The following is a description of a gene set: Human Gene Set: GSE29618_BCELL_VS_MONOCYTE_DN species: Homo sapiens Systems vaccinology has emerged as an interdisciplinary field that combines systems wide measurements and network and predictive modeling applied to vaccinology. Here we used the systems vaccinology approach to study the molecular mechanisms underlying th from publication Nakaya HI, Wrammert J, Lee EK, Racioppi L, Marie-Kunze S, Haining WN, Means AR, Kasturi SP, Khan N, Li GM, McCausland M, Kanchan V, Kokko KE, Li S, Elbein R, Mehta AK, Aderem A, Subbarao K, Ahmed R, Pulendran B (PMID 21743478) Genes down-regulated in comparison of B cells versus monocytes., and this is the list of marker genes: MIR22HG, GNG5, ATP6V1A, CTSL, RAB20, RNF130, ACTN1, NAIP, RHOG, CDA, CLEC4A, PTAFR, GSTO1, RBM47, MYO1F, SVIL, OTULINL, RTN4, ATP6AP2, NCOA4, GAB2, LRP1, RHOA, CNIH4, ATP6V0C, CNBP, C5AR1, NPL, CXCL2, SERINC5, CAPN2, AHR, ADGRE2, GNS, PILRA, RCBTB2, CCR1 (C-C motif chemokine receptor 1), CPPED1, HSBP1, CDC42EP3, CD44, MYD88, CTSS, PTGS2, GLRX, GRPEL1, HBEGF, USP3, FBXL5, MPP1 (MAGUK p55 scaffold protein 1), TPP1, PGK1, SLCO3A1, CD14, TIMP1, EPB41L3 (NCBI Gene Id 8730), RAB32, TIAM1, CREG1, DAPK1, CD63, RIN2 (Ras and Rab interactor 2), ALDH3B1, SLC27A3, TLR4, CD300A, GNAQ, BST1, KLF4, LILRA5, RAP2B, ADA2, COTL1, DENND5A, TRIB1, MTMR11, CDC42EP4, HMOX1, FTL, NAGA, SELPLG, PID1, ATP6V1B2, IL17RA, LILRB3, IFNGR1, RXRA, QPCT, SLC7A7, MCTP1, AOAH, SOD2, QSOX1, ARPC2, TSPAN14, TCF7L2, DUSP6, MGAT1, GIMAP4, FKBP1A, BLVRA, SDCBP, CD33, VEGFA, PEA15, RAB31, ITM2B, ITGB2, PTTG1IP, PPP2R3C, IGFBP7, ZDHHC7, PKM, RTN3, PSAP, RAB5IF, PLAUR, PLIN3, ZMIZ1, NDFIP1, AMPD2, RTN1, CD68, CEBPD, ANXA5, RNASE2, LTA4H, PLEK, PAK1, SQOR, ENO1, NLRP3, PECAM1, VAMP3, CHP1, CTSA (cathepsin A), CYFIP1, ACSL1, WDFY3, NOTCH2, CTSB, CEBPA, SULT1A2, CASP1, OAZ1, ZFAND5, TBXAS1, PICALM, TPI1, CD93, CS, PTX3, HPSE, IFI30, SLC31A2, KIAA0513, FYB1, CSF3R, METTL9, PXN, SMARCD3, BLVRB, CALML4, FBP1, GMFG, STOM, EXT1, TREM1 (NCBI Gene Id 54210), SFXN3, FUT4, WARS1, NIPSNAP2, TPD52L2, CREB5, ULK2, SEC11A, HSD17B11, S100A11, BEST1, ASGR2, VAMP8, CAPZA2, S100A6, DPYD, AP1S2, MACROH2A1, STXBP2, CAST, GABARAP, PYCARD, DPYSL2, ADAM9 (ADAM metallopeptidase domain 9), FZD1, MAFB, UBE2D1, MYL6, LILRA2, PCSK5, VIM, CRISPLD2